Given this list of marker genes Foxd1, Nf1, Tmeff1, Eif5a2, Baz2b, Maml1, Rad23b, Ide, Fbxo45, Usp45, Arid5b (NCBI Gene Id 71371), Adamts6, Itpk1, Rab23, Meox2, Calu, Map3k21, Etaa1, Tdg, Gpt2, Papola, Dock7, Apaf1, Rasa1 (RAS p21 protein activator 1), Bdp1, Omg, Lamp3, Zdhhc17, Znrf1, Ccnjl, Lox, Map6, Snrpn, Ifngr1, Plxnc1, Ccdc6, Rgs17, Dsc2, Fam199x, Per2, Tnrc6a, Rab38, Kmt2c, Pip4k2b, Stx2, Sel1l3, Ywhaz, Klf10, Atg12, Vat1, Ypel5, Terb2, Gper1, Sos1, Itga8, Ell2, Fkbp3, Ccn4, Cop1, Ttll7, Gabra5, Mdm4 (NCBI Gene Id 98570), Socs3, Cfap61, Wipf1, Cacnb2, Reep3, Slc12a6, Psd3, Fign, Zbtb41, Pcgf5, Tasp1, Hycc1, Erg, Ncam1 (NCBI Gene Id 17967), Tmem87a (transmembrane protein 87A), Slc35c1, Lin7c, Ccne2, Lpar3, Zfp518a, Nr6a1, Sh2b3, Tle1, Dcun1d3, Mier3, Vat1l (NCBI Gene Id 270097, vesicle amine transport protein 1 like), Mlxip, Klf9, Sh3rf1, Zfp770, Mboat1, Atp2a2, Tbc1d15, Ppp3r1, Srsf7, Scn8a, 4933409G03Rik, Mcf2l, Slc38a2, Rfx6, Chd7, Crkl, Rapgef4, Fndc3a, Slc38a7, Sypl1, Myh11, Lin28a (NCBI Gene Id 83557), Ppp3ca, Atp2b2, Ap3s1, Tcaf3, Xpr1 (xenotropic and polytropic retrovirus receptor 1), Slc35a3, Rab15, Spast, Ccnt2, Spcs3, Larp4, Fam91a1, Sdad1 (SDA1 domain containing 1), Trip12, Stk35, Pou3f4, Exo5, Zmynd8, Map3k2, Ssx2ip, Nabp1, Tmem121, Carf, Mmd, Gria2, Slc7a6, Cpne8, Samd4 (NCBI Gene Id 78475), Dlgap2, E2f7, Zfp644, Edem3, Rimklb, Rassf10, Epc2, Zfp560, Slc15a2, Usp47, Ythdf3, Cadm2, Stxbp5, Fbxo42, Cfl2, Htr4, Pax3, C9orf72, Lrfn2, Pgm1, Bnip3l, Nus1, Slc38a4, Eml4 (echinoderm microtubule associated protein like 4), Nanos1, Tab3, Prdm1, Mex3b, Col13a1, Wwtr1 (WW domain containing transcription regulator 1), Rabgap1l, Plagl2, Dlg5, Prickle1, Itgb3, Proser1, Glce, Vmn1r71, Actc1, Dolpp1, Mast4, Lgi1, Ube3c, Eml1, Eed, Scn1a, Pip4k2a, Hic2, Slc35f3, Ube2i (NCBI Gene Id 76085), Nefl, Tcp11l2, Usp48, Myo9b, Ascc3, Wdr82 (WD repeat domain containing 82), Afap1l2, Cyb561, Lrrc17 (leucine rich repeat containing 17), Ccdc43, Nap1l5, Itgbl1, Tcstv2c, Amotl2, Camk2n1, Smap1, Plxna1, Plekho2 (pleckstrin homology domain containing, family O member 2), Herc6, Csnk1a1, Arid1a, Rfx7, Septin8, Atp6v1c1, Sema6d, Adam19, Abcc9, Cep170b, Bmp5, Rora, Rab2b, Lmbr1l, Ip6k3, Garre1, Tbl1xr1, Foxb1, Zdhhc20, Gnai1, Rhebl1, Stag2, Ccnk, Actr1a, Ednra, Map3k12, Nr5a2, Zcchc2, Edn2, Ifi213, Avl9, Mfsd6, Celf4, Bnc1, Rrad, Siah2, Irx4, Capza1, Setd5, Lrp6, Rundc3b, Chst1, Ark2c, Ado, Gpr180, Naaladl2, Lcorl, Galnt2 (polypeptide N-acetylgalactosaminyltransferase 2), Gzf1, Gmeb2, Rimbp2, Mbtps2, Cnot9, Galnt7, Ankrd55, Sema3a, Mfsd11, Rasd1, Ptpn13, Shoc2, Tbc1d30 (TBC1 domain family, member 30), Klhl20, Lrrc40, Frmpd1, Apba1, Capn7, Tnrc6b, Mafg, Cep170, Nrxn3, Chl1, Wipf3, Six1, Pptc7, Vip, Rapgef2, Macroh2a1, Dpy19l1, Rasa2, Prkaa2, Slc35f4 (solute carrier family 35, member F4), Cracdl, Camta1, Calcr, Ppp1r1c, Ptpn21, Gpcpd1, Cep350, Kctd8, Celsr3, Taok1, Mttp, Dio2, Ddit4, Bahd1 (bromo adjacent homology domain containing 1), Cpsf6, Gldc, Bcor, Cdca7 (cell division cycle associated 7), Asb3, Fam83f, Xpo1, Spen, Zfp608, Dpysl2, Chka, Zfp521, Col9a3, Haus4, Socs1, Scn3a, Smad1, Chd1, Sgk3, Snai1, Nhlh2, Dgkq, Nfat5, St8sia4, Tet1, Rap2c, Impact, Snx18, Sema6b, Zfp36l2, Stac, Rps6ka5, Lifr, Csnk1g1, Rnf122, Foxg1, Ppp4r4, Ppp1r12a, Kcnmb2, Washc4, Mbnl3, Mybl2, Il21r, Six4 (sine oculis-related homeobox 4), Usp37, Elmod2, Slc35f1, Tcfl5, Phtf2, Ptpn2, Terf1, Zfp507, Nt5e, Slc4a7, Dnmt3a, Ror1, Elavl2, Fst, Becn1 (NCBI Gene Id 56208), Hbs1l, Edc3, Snapin, Plekhm3, Gja1, Adra2a, Brd1, Capn5, Tbc1d10b, Mzt1, Epb41l3, Lpp, Mier2, Exoc6, Tia1, Cblb, Rai14, Neurl1b, Nfatc3, Prps1l3, Strip1, Ptgfrn, Brwd3, B4galt6, Atosa, Grm3, Mab21l1, Hycc2, Extl2, Zbtb34, Dnajc13, Atg3, Gtf2h4, Tmem200a, Tenm3, Pik3cd, Ssh2, Ankrd17, Trpm7, Oxr1, Plppr4, Rab32, Ccdc71l, Camkk2, Ubn1, Kdm3a, Det1 (NCBI Gene Id 76375), Twf1, Camk2d, Large1 (NCBI Gene Id 17871), Picalm, Tent5a, Efna3, Runx1, Gm4871, Sall4, Prlr, Abcd2, Erlin1, Ube2v2, Syngr3, Slc41a2, Ric3, Fam43a, Ppid, Ndel1, Vim, Lrrk2, Cth, Sgcb, Adam9, Hecw1, Ppp2r1b, Ap4e1, Ypel2, Cysltr1, Asah1, Scel, Cthrc1, Mat2a, Ubn2, Tulp4, Skp2, Acvr1, Ddah1, Myo5a, Bnc2, Cyp24a1 (cytochrome P450, family 24, subfamily a, polypeptide 1), Tmod2, Necap1, Flvcr1, Adgra3, Cbfb (core binding factor beta), Lpgat1, Cand1, Tepsin, Sirt1, Pon2, Lhx8, Desi2, Scara5, Dennd2c, Psmd7, Kcna4 (NCBI Gene Id 269325), Ago1, Mical1, Jarid2, Pank3, Bcl2l11, Gnai2, Vkorc1l1, Scn2a, Tfdp1, Pawr, Cadps, Rnf157 (ring finger protein 157), Lipi, Stim2, Jakmip2, Man1a2, Ntng1, Stk39, Hdac9, Pcdh17, Marchf4, Ppargc1a, Plch1, Mfap5, Frzb, Jdp2, Map3k13, Zbtb18, Slc7a10, Pdcd5, Elovl5, Dcbld1, Ttbk1, Mitd1, Atxn1, Stox2, Ano4, Tecrl, Galr1, Irs1, Rasgef1a, Rnf220, Nedd4, Chst2, Sh3pxd2a, Ago3, Nsg1, Zdhhc21 (NCBI Gene Id 68268), Rbm44, Ap1s2, Arid4a, Cnot6, Ddx19b, Erich5, Rap1b, Dcun1d1, Esyt3, Nhsl3, Ppp3cb (NCBI Gene Id 66215), Fosl2, Sox9, Sptssb, Osbpl8, Cul2, Glcci1, Mtdh, Lonrf1, Dlgap4, Atp6v0d1, Adra1d, Rps6ka2, Fbln5, Tnrc6c, Coq3, Fhip2a, Brd10, Slc35d3, Vopp1, Ptp4a1, Pcnx2, Tent2, Fzd3, Cnr1, Klf8, Cdh20, Ankhd1, Pnkd, Cep41, Usp50, Gjc2, Dgkz, Cilk1, Ino80d, Clock, Cdc37l1, Xkr4, Sytl4, Sec24a, Polr3g, Jph4, Sec24d, Nagpa, Pfn2, R3hdm1, Ube2j1, Wdr7 (NCBI Gene Id 56065), Ppp1r18, Fam13c, Trappc14, Zcchc24, Septin7 (septin 7), Kctd7, Jade3, Nlgn1, Nrg3, Limch1, Snx16, Unc5c, Ercc6l2, Ankra2 (NCBI Gene Id 68558), Lin28b, Snx33, Sp4, Pde7a, Gli2, Setd7, Gmeb1, Dll4, Map3k5, Nedd4l (NCBI Gene Id 83814), Trp53inp1, Tnxb, Galnt1, Katnbl1, Mkrn3, Hnrnpul2 (NCBI Gene Id 68693), Adamts3, Samd8, Scn9a, Phactr2, Tmem170b, Gigyf2, Zfp420, Runx2, Aox2, Gna13, Ppargc1b, Fnip2 (NCBI Gene Id 329679), Oga, Azin1, Esco1, Gatm, Sec23a, Elavl4, Rgs8, A630023A22Rik, Kras (NCBI Gene Id 232521), Reep1, Piezo2, Arhgef6, Galnt3, Pdss1, Slc36a1 (NCBI Gene Id 76010), Fbxo32, Pdlim5, Tmem181a, Yaf2, Khnyn, Lclat1, Rbm46, Nadk, Msi2, Gabrb1, Pbrm1, Slc30a4, B3gnt5, Dact1, Evx2, Hectd2, Epb41 (erythrocyte membrane protein band 4.1), Polr3e, Nrk, Dsg2 (NCBI Gene Id 52489), Rarg, 0610040J01Rik, here is a description of the gene set: from publication Chen Y, Wang X (PMID 31504780) species: Mus musculus Genes predicted to be targets of miRBase v22 microRNA mmu_miR_30a_5p, mmu_miR_30e_5p in miRDB v6.0 with MirTarget v4 prediction scores > 80 (high confidence targets). Mouse Gene Set: MIR_30A_5P_MIR_30E_5P